Given this list of marker genes EP300, GPC3, NIPBL, COL1A1, ATP6AP2, SSBP3, FUZ, MAB21L2, MSX1, NCKAP1, NOG, CRISPLD1, OFD1, TGFB1, TBX1, ZNF281, ANKRD11, CSRNP1, WNT3, CRISPLD2, ARID5B, TGFB3, SKI, FLVCR1, BRAF (NCBI Gene Id 673), PTPN11, SCX, PAX9 (paired box 9), STRA6, ASPH, VPS13B, SGPL1, RRAS, PLEKHA1, LEF1, TGFB2, PRICKLE1, CDON, MYH3, DLX5, IFT122, TIPARP, GREM2, MMP2, DKK1, CLDN5, IHH, RAB3GAP1, PDGFRA, here is a description of the gene set: Human Gene Set: GOBP_BODY_MORPHOGENESIS The process in which the anatomical structures of the soma are generated and organized. studied in species Homo sapiens